Given this list of marker genes Psme1, Itpripl1 (inositol 1,4,5-triphosphate receptor interacting protein-like 1), Scn4a, St3gal4, Nav1, Anxa13, Pkd2l1, Dcx, Car5b, Ooep, Cbx5, Cers2, Emc1, Bcr, Cep170b, Atad3a, 2310022A10Rik, Cnnm1, Atp2b4, Gad2, Tead1, Zfp385a, Agpat1, Rufy2, Drg2, Ednra, Fam131b, Mbd6, Hspe1, Rigi, Hoxc10, Otub1, Map3k20, Kir3dl2, Myadm, Ehf, Krt8, Ddn, Fam168a, Phactr4, Afap1, Ndufs4, Nr6a1, Knop1, Rab43, Arrb2, Rapgef1, Elk1, Lin28b, Rnf14, Cadm3, Trank1, Abhd2, Klc2 (NCBI Gene Id 16594), Myrf, Htt, Nfatc1, Cst6, Acsf2, Pla2r1, Orai3, Rps15a, Ephb2, Vps25, Ms4a10, Uhrf2, Hyal3, Tmem132e, Mapt, Ahdc1, Ywhaz, Coq8b, F2rl2, Sgsm1 (small G protein signaling modulator 1), Psd2, Ulbp1, Mrpl40, Lonrf2, Yju2b, Gtse1, Adtrp, Izumo1r, Tnrc6b, Susd1, Pianp, Gmip, Cxcr5, Ankrd49, Usp45, Trmt10a, Slc8b1, Crybg1, Ubl4a, Ldlrad2, Lrrc38, Leng8, Laptm5, Eif4ebp2 (eukaryotic translation initiation factor 4E binding protein 2), Dhx15 (NCBI Gene Id 13204), Sapcd2, Sv2a, Wnt1, B4galt2, Rbms2, Pde7a, Zhx3, Rasl10b, Dgcr8, Tox4, Shmt2, Dmtn, Nrf1, Cep85, Slc38a10, Rpap2, Pacs1, Mmp15, P2rx3 (purinergic receptor P2X, ligand-gated ion channel, 3), Cdyl2, Sec22c, Atxn1, Chd3, Nmrk2, Mtcl2, Yy1, Papolg (poly(A) polymerase gamma), Syt15, Dpf3, Ppm1b (NCBI Gene Id 19043), Fa2h (fatty acid 2-hydroxylase), Pim1, Ankrd40, Cdr2l, Ube3a, Sdc3 (syndecan 3), Pou6f1, Cts8, Samd8, Atxn1l, Ttll1, Abitram, Shisal1, Lbh, Ddx51, Cd2bp2, Pik3r1, Sbspon, Dtwd2 (NCBI Gene Id 68857), Acmsd, Dis3l, Shisa7, Smco1, Cutal, Gnl3l, Prkaca, Ttll9, Mpp2, Coro2b, Rbbp5, here is a description of the gene set: Mouse Gene Set: MIR_6979_5P Genes predicted to be targets of miRBase v22 microRNA mmu_miR_6979_5p in miRDB v6.0 with MirTarget v4 prediction scores > 80 (high confidence targets). studied in species Mus musculus from publication Chen Y, Wang X (PMID 31504780)